Given this list of marker genes OPHN1, SNX14, ZSWIM6, TMTC3, PDGFRB, GRM1, GRIA3, AHDC1, DOCK6, here is a description of the gene set: Retrocerebellar cyst Human Gene Set: HP_RETROCEREBELLAR_CYST studied in species Homo sapiens